The following is a description of a gene set: Human Gene Set: HP_WIDELY_PATENT_FONTANELLES_AND_SUTURES An abnormally increased width of the cranial fontanelles and sutures. Widely patent fontanelles and sutures studied in species Homo sapiens, and this is the list of marker genes: RBM10 (NCBI Gene Id 8241), ALPL, PEX1, CYP27B1, SLC34A3, VDR, POLR3A, LMNA, MED12, MSX2, AGT, SETBP1, AGTR1, ZMPSTE24, ACE, CYP2R1, REN (NCBI Gene Id 5972)